Given this list of marker genes Abcb1a, Arid4a, Flna, Gja1 (NCBI Gene Id 14609), Icam1, Arid4b, Il1a, Rab13, Cftr, here is a description of the gene set: Mouse Gene Set: GOBP_ESTABLISHMENT_OF_SERTOLI_CELL_BARRIER Establishment of a structure near the basement membrane in adjacent Sertoli cells of the seminiferous epithelium for maintaining spermatogenesis. The structure consists of tight junctions, basal ectoplasmic specializations, and desmosome-like junctions. studied in species Mus musculus